The following is a description of a gene set: from publication Chen Y, Wang X (PMID 31504780) Human Gene Set: MIR141_5P studied in species Homo sapiens Genes predicted to be targets of miRBase v22 microRNA hsa-miR-141-5p in miRDB v6.0 with MirTarget v4 prediction scores > 80 (high confidence targets)., and this is the list of marker genes: FAM135A, EFHD2, FBXL16, QKI, DARS2, ERBIN, ANKRD7, PRKACB, GLYATL1, EGFR, ZNF334, BEND2, METTL9, NPY5R, DLC1, SCLY, MAP3K1, SUPT16H, COG2, TM9SF3, SLC33A1, LMLN, TPH2, CBLL1, TXNDC5, ITGA9, ANKRD44, KCTD6, SGK1, DNAJC21, RRP15, PTCHD4, NETO1, RANBP6, MAP3K7CL, FRAS1, FBXO33, SPINK14, KIAA1671, ST7L, CCDC85A, NTNG1 (netrin G1), PHRF1, GTF2B, SLC30A9, INO80D, TLNRD1, ATP6V1G3, UBE2W, FXN, CDO1, CEP44, GRPEL1, MORC1, MAP3K20 (NCBI Gene Id 51784), RAB32, ROPN1, CAMK1, ZFYVE9, UVRAG, HAPSTR1, MCEMP1, NAPG, SPTSSA (serine palmitoyltransferase small subunit A), TBC1D12, ONECUT2, WNT5A, IPMK, TRIB2, GCFC2, RSPH4A, CDR1, DDX19B, PLA2R1, NEK11, ZNF695, KDM7A, CDH19, MATN2, CRYZL1, ILDR2, SMIM17, MAN2A1, MCTP1, HSP90AA1, TCAF1, SNTG1, TENT4B, GRIA4, SOAT1, TBX18, COL21A1, RREB1, CA8, SEL1L, CDKN1B, NUP50, CD46